Given this list of marker genes Abcc1, Kcnj11, Abcd1, Eif2s1, Psmc1, Psmd12, Abcd2, Abca5, Psmc5, Rps27a, Abca6, Cftr, Abcc6, Abcb6, Psmd1, Derl3, Sel1l, Abcc9, Psma3, Abca2, Derl2, Psmb7, Adrm1, Psmd8, Abcg5, Abca4, Abcb8, Eif2s3x, Psma1, Psmd13, Abcb9, Psmb2, Abcg4, Psmb5, Psmd3, Pex19, Psmc4, Psma7, Abcf1, Psma4 (proteasome subunit alpha 4), Abcc2, Os9, Psmc3, Psmd2, Abcb7, Eif2s2, Rnf185, Psmc2, Abcc3, Psma6, Psmd14, Psmb6, Abcb1a, Vcp, Abca3, Abca8b, Erlin2, Ubb, Rnf5 (ring finger protein 5), Psmd11, Erlec1, Pex3, Abcc10, Abca12, Psma2 (proteasome subunit alpha 2), Psmd7, Uba52, Abcd3, Abcc4, Psmb3, Abcg1, Psma5, Psmd6, Apoa1 (NCBI Gene Id 11806), Abcc5, Abcg8, Abca9, Erlin1, Abcb4, Abca7, Uba52rt, Psmb1, Derl1, Psmb4 (proteasome (prosome, macropain) subunit, beta type 4), Ubc, Abcb5, Psmc6, here is a description of the gene set: Mouse Gene Set: REACTOME_ABC_FAMILY_PROTEINS_MEDIATED_TRANSPORT ABC-family proteins mediated transport species: Mus musculus